Given this list of marker genes ACADSB, CHTF8, DNAJC8, PARP9, DYDC2, TMTC1, ACKR2, NID1 (NCBI Gene Id 4811), CDADC1, TRAF3IP2, ZNF814, ZNF544, SAMD4A, CPSF7, CYP2B6, CYP20A1, VPS25, DAB2IP (DAB2 interacting protein), DDX6, CORO2B, OSBPL1A, CCDC28A-AS1, SUSD5, NOL9, PNMA2, MTFMT, RAB21, ELK1, LHPP, MTX3, VPS13B, TMEM132E, PDE7A, MAPK13, SYNGR1 (NCBI Gene Id 9145), MASP1, NSL1 (NSL1 component of MIS12 kinetochore complex), ITLN1, FBXL20, DMRT1, EBAG9, MS4A10, GFRA4, HRH2, MRPS2, PIGK, CASP10, ARID2, GNAT1, CD164, ASPG, CTDSPL (CTD small phosphatase like), EEF2K, LYZL2, HUNK, ZNF793, NMNAT2, GCFC2, FAM72A, CTSW, SYBU, YWHAQ, IGF2BP1, BMAL2, GNPNAT1, CDK8, CALCR, ODAPH, UPK2, ZNF554, POLR2D, ANKS4B, SV2C, MIP, DTX4, MDM4, COL11A2, PSMB2 (NCBI Gene Id 5690), COL27A1, PYGO1, SBSPON, SCAI, SHISA6, APOL6, CGNL1, MYO10, GNL3L, FIBCD1, RIMS3, GLG1, GFAP, ATP1B4, DCTN5, NCEH1, LYZL1, NDST1, KCNIP1, NOVA2, ZNF490, GAB2, PPP1R11, CDH1, PRND, FOXK1, MS4A1 (NCBI Gene Id 931), CBX5, SETD7 (SET domain containing 7, histone lysine methyltransferase), CCL28, PAPOLG, HOOK3, ZNF655, ERBB3, GDI1, RPL15, TMEM265, ZDHHC15, SHOX, EOGT, IRGQ, SH3BP2 (NCBI Gene Id 91018), SCGN, ZFHX2, CYP1A2, FUS, PLEKHA5, SYP, SULT1E1, SHISA7, ARGFX, ORAI2, STX5, IKZF3, GPR83, FBXL18, TCTN2, PHACTR4, APELA, FAM72B, PYCR3, TMEM239, FOXP4, RRP7A, ARNT2, APOBEC3F, GLS, DEPDC5, ESYT1, RHOJ, EFCAB2, MAVS, MARK4, ZNF674 (zinc finger protein 674), TIAM1-AS1, RALB, SLC6A11, CEBPZOS, VIRMA, PI3, TMEM63C, PACS1, MTCL2, CASTOR2, GFOD2, RRP15, ZNF286B, ATP7B, PRICKLE3, LRRC51, RBMS2, ATXN1, CSF3R, ZNF432, PLCXD1 (phosphatidylinositol specific phospholipase C X domain containing 1), RBM19, SLC2A4, RAD51B, MUCL3, here is a description of the gene set: from publication Chen Y, Wang X (PMID 31504780) Genes predicted to be targets of miRBase v22 microRNA hsa-miR-3689a-3p, hsa-miR-3689b-3p, hsa-miR-3689c in miRDB v6.0 with MirTarget v4 prediction scores > 80 (high confidence targets). Human Gene Set: MIR3689A_3P_MIR3689B_3P_MIR3689C species: Homo sapiens